The following is a description of a gene set: Human Gene Set: GOMF_NAD_P_H_DEHYDROGENASE_QUINONE_ACTIVITY Catalysis of the reaction: NAD(P)H + H+ + a quinone = NAD(P)+ + a quinol. studied in species Homo sapiens, and this is the list of marker genes: CBR3, NQO1, CBR4, NQO2 (N-ribosyldihydronicotinamide:quinone dehydrogenase 2), RTN4IP1